Given this list of marker genes PIGR, MLLT6, CHRDL1, OLFML1, STK35, RBMX, DNAJB5, SLC30A4, PCGF1, CBX6, CCN4, NR2F2, ITGA3, PTBP3, HPCA, H2AZ1, SAMD7, ZFHX3, PISD, GJC1, HSD11B1, KRTAP17-1, SND1, ZMYM4, MEIS1, PSD2, VASH1, SEC14L2, FBXO2, ZFP91, GCNT1, EPB41, ZNF462, HPSE2, APOBEC4, RFX5, PELI2, NIPBL, CSRNP2, C8orf17 (NCBI Gene Id 56988), TP53BP1, ARFIP2, USP34, LARP1, GMFB, FBXW4, WNT5A, TBCC, PHETA1, DVL3, MAPK10, ADAMTS5, GHDC, SDC4, GPR63, ADD3, ELP4 (elongator acetyltransferase complex subunit 4), DLG1, CHD4, IMMP1L, BCL11B, FBXO44, KLF7, CATIP, SLC26A6, SZRD1, NTF3, AXL, KRT85, HYAL2, RPL4, PCDH8, GPX2, CLN3, C18orf21, NLGN3, OSR2, SETD7, ETV6, SIX1, NRL, PMEPA1, SMAD6, FKBP8, DPF3, PLCD4, ZBTB7A, ELAVL4, ACTR1B, SLC7A10, TGFBR1, PRSS36, TMEM154, MMP15, DCP1A, NR2E1, ARL4C, MPL, TEKT4 (NCBI Gene Id 150483), ADTRP, TSPAN3, MGAM, LMNA, INO80, TRMT9B, IRF2BP1, DTX1, MBNL1, PRICKLE1, P3H2, ADCY8, SP8, EMILIN1, IER5, GPHN, NR2C2AP, RNF44, LDB3, HYCC1, TEK, RNF19A, OR13C9, BLTP3A, TPMT, NTRK3, TIMM10B, CYTH3, POU3F3, TPGS2, PATL1, TMEM229B, ATP6V0A1, ZWILCH, MACO1, here is a description of the gene set: from publication Xie X, Lu J, Kulbokas EJ, Golub TR, Mootha V, Lindblad-Toh K, Lander ES, Kellis M (PMID 15735639) Comprehensive identification of all functional elements encoded in the human genome is a fundamental need in biomedical research. Here, we present a comparative analysis of the human, mouse, rat and dog genomes to create a systematic catalogue of common regulatory motifs in promoters and 3' untranslated regions (3' UTRs). The promoter analysis yields 174 candidate motifs, including most previously known transcription-factor binding sites and 105 new motifs. The 3'-UTR analysis yields 106 motifs likely to be involved in post-transcriptional regulation. Nearly one-half are associated with microRNAs (miRNAs), leading to the discovery of many new miRNA genes and their likely target genes. Our results suggest that previous estimates of the number of human miRNA genes were low, and that miRNAs regulate at least 20% of human genes. The overall results provide a systematic view of gene regulation in the human, which will be refined as additional mammalian genomes become available. Genes having at least one occurrence of the highly conserved motif M167 CCTNTMAGA in the regions spanning 4 kb centered on their transcription starting sites. The motif does not match any known transcription factor binding site. studied in species Homo sapiens Human Gene Set: CCTNTMAGA_UNKNOWN